Given this list of marker genes TCEANC2, PNKD, RBM24, OPA3, HCFC1R1, RARA, TMEM59 (NCBI Gene Id 9528), ARID5A, SMCR8, SERTAD3, ZBTB9, DYM, MDH1, RBM41, INVS, TSPAN2 (NCBI Gene Id 10100), MVB12A, CALCOCO1, NOS3 (NCBI Gene Id 4846), DCAKD, SLC38A9, RNF10, WNT9A, ZNF570, AAMP, LARS1, HACE1, CBLL1, TTLL4, CNFN, PRUNE2, TMEM208, ZNF180, ZC3H11A, NUDCD1, ATXN7L2, MITF, SPEF1, FAM78A, DMD, HAUS1, BUB1B, PRCC, CHM, AQP4-AS1, PEX26, DTX2, ATP5F1A, NMT1, MYO1E, ZNF233, UTP11, COX14, DPM3, RDH11 (retinol dehydrogenase 11), WBP2, UBE2H, TRIP10 (NCBI Gene Id 9322), CHPF, ZNF546, PSMD4, DCUN1D4, MIER3, PLPP7, AQP4, ZC4H2, SLITRK2, STK10, CIAO1 (cytosolic iron-sulfur assembly component 1), CNIH2, TMEM132E, SESN2, RAB1B, ZNF569, BET1, NFXL1, ZNF875, NUDT13, INTS9, TMEM127, TNFAIP8L2, FBXL9P, TOP3A, AAK1 (NCBI Gene Id 652453), HMBOX1, MSL3, THOC6, FERD3L, TIAL1, IFTAP, MRPL42, JARID2, UBXN8, CCDC25, NRDE2, here is a description of the gene set: studied in species Homo sapiens Comprehensive identification of all functional elements encoded in the human genome is a fundamental need in biomedical research. Here, we present a comparative analysis of the human, mouse, rat and dog genomes to create a systematic catalogue of common regulatory motifs in promoters and 3' untranslated regions (3' UTRs). The promoter analysis yields 174 candidate motifs, including most previously known transcription-factor binding sites and 105 new motifs. The 3'-UTR analysis yields 106 motifs likely to be involved in post-transcriptional regulation. Nearly one-half are associated with microRNAs (miRNAs), leading to the discovery of many new miRNA genes and their likely target genes. Our results suggest that previous estimates of the number of human miRNA genes were low, and that miRNAs regulate at least 20% of human genes. The overall results provide a systematic view of gene regulation in the human, which will be refined as additional mammalian genomes become available. Genes having at least one occurrence of the highly conserved motif M80 SNACANNNYSYAGA in the regions spanning 4 kb centered on their transcription starting sites. The motif does not match any known transcription factor binding site. from publication Xie X, Lu J, Kulbokas EJ, Golub TR, Mootha V, Lindblad-Toh K, Lander ES, Kellis M (PMID 15735639) Human Gene Set: SNACANNNYSYAGA_UNKNOWN